The following is a description of a gene set: Human Gene Set: chr11q22 species: Homo sapiens, and this is the list of marker genes: BOLA3P1, ZC3H12C, YAP1, CYCSP29, EXPH5 (NCBI Gene Id 23086), MTND1P36, OR2AL1P, MIR4693, DCUN1D5, DDI1, KBTBD3, MMP3, MMP8, CFAP300, ELMOD1, ALKBH8, CARD16, ENSG00000290498, CWF19L2, GUCY1A2, TMEM123, RNU7-159P, TMEM123-DT, MMP27, RNU6-654P (RNA, U6 small nuclear 654, pseudogene), RNA5SP347, LINC02713, CARD18, RNU6-952P, CASP1P2, BIRC3, ACAT1 (NCBI Gene Id 38), TFAMP2, CASP1P1, FDX1, PLS1P1, RPS2P39, ATM, LINC02552, MSANTD4, LINC02719, CASP5, ARHGAP42-AS1, RN7SL222P, POGLUT3, RPL21P96, MMP1, PPIAP43, NPAT (nuclear protein, coactivator of histone transcription), ARHGAP42, PDGFD, RAB39A, HSPD1P13, MTMR12P1, MMP7, METTL5P4, LINC02715, RPA2P3, CASP12, MTND2P26, WTAPP1, SLN, LINC02732, PGR, SNORD55, RPSAP50, PDGFDDN, CNTN5, CUL5, CEP126 (NCBI Gene Id 57562), ENSG00000303649, GRIA4, C11orf65, RNA5SP349, MMP20, MMP12 (NCBI Gene Id 4321), MTCO3P15, CASP4LP, KIAA1191P2, MTCO1P15, MMP13, MIR3920, PGR-AS1, MTCO2P15, DDX10, MTATP6P15, C11orf87, RNU4-55P, SMARCE1P1, RN7SKP115, ANGPTL5, RDX, CASP1, RN7SKP53, RNA5SP535, TRPC6, AASDHPPT, RNU6-277P, CASP4, MMP10, MMP20-AS1, ENSG00000255482, SLC35F2, DYNC2H1 (NCBI Gene Id 79659), BIRC2, CARD17P, ASS1P13